The following is a description of a gene set: studied in species Mus musculus Mouse Gene Set: GOBP_RECEPTOR_LOCALIZATION_TO_NON_MOTILE_CILIUM A process in which a receptor is transported to, or maintained in, a location within a non-motile cilium., and this is the list of marker genes: Arl13b, Tub, Arl13a, Bbip1, Ift80